Given this list of marker genes BCL11B, FMO4, MCUR1, IVL, DHRS7B, MYCL, KLF3, TAOK1, TMEM132C, HAUS4, TMEM200A, TRIM43B, MBNL1, PPM1B, NRAS, XRCC5, RECQL, QKI, DNAJC27, BAHD1, FOXN2, TOR1B, BIRC2, LDLRAD4, SKI, TBCE, TMEM35A, ITIH6, CLRN1, ZSWIM3, RANBP1, EIF1, BPY2C, WDFY2, KPNA1, WAC, BNIP2, TCF12, NTM, CCDC110, PCDH20, HLCS, TRIM44, LSG1, BPY2, POLR3C, BPY2B, TOX3, GNG12, RNF169, EBF1, PUS7L, PCMT1, HECTD1, RBM24, TRIM43, VAPB, NLGN1, IRF2BP2, FHIP2A, WWTR1, TMEM213, GPBP1L1, TXNDC5, here is a description of the gene set: Human Gene Set: MIR6780B_3P from publication Chen Y, Wang X (PMID 31504780) Genes predicted to be targets of miRBase v22 microRNA hsa-miR-6780b-3p in miRDB v6.0 with MirTarget v4 prediction scores > 80 (high confidence targets). species: Homo sapiens